The following is a description of a gene set: studied in species Homo sapiens Human Gene Set: GOMF_PHOSPHATIDYLINOSITOL_PHOSPHATE_5_PHOSPHATASE_ACTIVITY Catalysis of the removal of the 5-phosphate group of a phosphatidylinositol phosphate., and this is the list of marker genes: INPP5E, PTPMT1, FIG4, SYNJ1, INPP5D, INPP5F, SYNJ2, INPP5K, PIKFYVE, OCRL, INPP5B, INPP5J, INPPL1, PTPRQ